Given this list of marker genes TUBB4A, DCX, ITGBL1, STX1B, KRTAP17-1, KCNA2, MYOZ1, RPL18 (NCBI Gene Id 6141), TFF3, DYDC2, PCLO, TMEM213, CLDN6, CPNE6, LHX3, PGBD5, UPP2, SAMD12, HOXC4, IRX1, TRAT1, GPRASP1, ADAM12, WEE2, GPR12, ABCG4, TBX19, REV3L, NRIP2, SIRPB1, RPS9, COPZ2, ST6GALNAC1, IFT88, RNF217, KRT2 (NCBI Gene Id 3849), LURAP1, BPIFB3, SLC35F1, EGFR, TMEM179, AJM1, MED18, TSHR, TMCC2, CTSK, NREP, DNM3, HTRA3, WNT7B, CELF3, KCNG4, ANGPT4, NPM1, GARIN2, IL36A, KRT35 (NCBI Gene Id 3886), SH3PXD2A, PRKCG, IL13RA1, WNT1, PRKAA2, PLA2G6, RNF122, RPL30, BPIFB2, FRMPD3 (FERM and PDZ domain containing 3), RARB, PLPPR1, BMPR1A, CLDN4, DUOXA2, CDH11, CABP5, FERMT2, PIK3IP1, GRIN2B, PCDHB7, TET3, BACE1 (NCBI Gene Id 23621), CYFIP1, FAM171A2, SLC5A4, SLC12A8, HRC, IGF2BP3, CSF3, ZFPM2 (NCBI Gene Id 56958), GSTM1, ARHGEF40, SVEP1, EPCAM, LCE2B, ACVR1, C2orf88, AZGP1, ADD2, APLP2, SOX7, CHRM1, TMEM266, MYO1D, C16orf86, IL7R, MEFV, BPIFA2, UROC1, CRB1, SCML2, ZEB2, COL6A1, PLAG1, PCDHB12, ADGRG3, MS4A7, SYN1 (NCBI Gene Id 6853), NTRK2, RAG2, FUT2, TEAD4, ADRA2A, SYP, EDAR, FMO2, RHOJ, KCNH1, SLC29A4, NPY, LRFN1, RHO, ZNF536, TTLL10, DLX4, MFAP2, JAKMIP2 (NCBI Gene Id 9832), GPC5, EHD2, TECTB (tectorin beta), VWC2L, RPL37, INTU, GNAL, SLC10A1, SLC26A3, ATP7B, SLC22A7, RAMP1, CPLANE2, ADAM28, RIMBP3C, ANGPTL7, ATP13A5, SMO, PKD1L2, BDKRB1, ANKRD33, PAX3, TPBG, BACE2, EPOR, PTCH2, BCAR3, TGFBR3, ADAMTS9, PRMT8, PAPSS2, ZNF112, CACNG6, BHLHE41, IGF2BP1, CASQ1, HAS3, EPN2, PLCL1, HOOK3, PAX1, VSX2, SPATA18, FBLN1, FOXA2, MEIKIN, ZFX, MYT1 (NCBI Gene Id 4661), RBFOX1, NXF2 (NCBI Gene Id 87110), ADGRE1, KPRP, ZP2, FSTL5, CCNJL, XPNPEP2, OR5P3, CD300LG, NLRP3, TMPRSS15, TMEM121B, SPARCL1, FBLIM1, SLC26A11 (solute carrier family 26 member 11), NCCRP1, here is a description of the gene set: Genes up-regulated in comparison of naive CD8 T cells versus effector CD8 IL2RA low T cells at. from publication Kalia V, Sarkar S, Subramaniam S, Haining WN, Smith KA, Ahmed R (PMID 20096608) CD25, the high affinity interleukin-2 (IL-2) receptor alpha-chain, is rapidly upregulated by antigen-specific CD8+ T cells after T cell receptor stimulation. We demonstrated that during an acute viral infection, CD25 expression was dynamic, and a subset of virus-specific CD8+ T cells sustained CD25 expression longer than the rest. Examination of the in vivo fate of effector CD8+ T cells exhibiting differential responsiveness to IL-2 revealed that CD25lo cells, which were relatively less sensitive to IL-2, preferentially upregulated CD127 and CD62L and gave rise to the functional long-lived memory pool. In contrast, CD25hi cells that accumulate enhanced IL-2 signals, proliferated more rapidly, were prone to apoptosis, exhibited a more pronounced effector phenotype, and appeared to be terminally differentiated. Sustained IL-2 receptor signaling resulted in increased CD8+ T cell proliferation, higher granzyme B expression and exaggerated contraction after antigen clearance. These data support the hypothesis that prolonged IL-2 signals during priming promote terminal effector differentiation of CD8+ T cells. Human Gene Set: GSE19825_NAIVE_VS_IL2RALOW_DAY3_EFF_CD8_TCELL_UP studied in species Homo sapiens